Given this list of marker genes Chrm3, Dock5 (dedicator of cytokinesis 5), Map2k1, Rhoa, Zdhhc21, Dock4, P2rx1, Adra2b, Stub1, Arhgap42, Atp2b1, Htr7 (NCBI Gene Id 15566), here is a description of the gene set: Mouse Gene Set: GOBP_REGULATION_OF_VASCULAR_ASSOCIATED_SMOOTH_MUSCLE_CONTRACTION species: Mus musculus Any process that increases the frequency, rate or extent of vascular smooth muscle contraction.